Given this list of marker genes HADHA, PECR, ACADM, EHHADH, ACSL1, ACADVL, SCP2, SLC22A5, CPT1A, ACSL4, ECI1, HADHB, ACADS, ACADL, CPT2, ACSL3, HADH, ACSF2, SLC25A20, here is a description of the gene set: species: Homo sapiens Mitochondrial fatty acid oxidation disorders Human Gene Set: WP_MITOCHONDRIAL_FATTY_ACID_OXIDATION_DISORDERS